Given this list of marker genes Crtc2, Trpv5, Tk1, Gria3, Upb1, Aldh1a2, Trpa1, Mcoln1, Pkm, Aqp2, Pkd2l1, Aqp5, Crtc1, Shmt1, Golga2, Cryz, Aqp4, Mat1a, Sod2, Sycp1, Hprt1, Trpv6, Kcnn4, Tdo2, Trpm7, Itpr1, Samhd1, Acacb, Vasp, Usp16, Dnm1, Evl, Appl2, Trpm2, Gls, Kcnt1, Mip, Cbr4, Gnmt, Ryr3, Hcn1, Thg1l, Trpv1, Acot13, Acaca, Gbp5, Aldh9a1, Crtc3, Hsd17b10, Aldh1a3, Kcnj12, Cby1, Ryr1, Apip, Ssbp1 (NCBI Gene Id 72790), Aldoa, Cth, Pkd2, Osbpl2, Trpm4 (transient receptor potential cation channel, subfamily M, member 4), Shmt2, Kcnj2, B2m, Itpr3, Me1, here is a description of the gene set: The formation of a protein homotetramer, a macromolecular structure consisting of four noncovalently associated identical subunits. studied in species Mus musculus Mouse Gene Set: GOBP_PROTEIN_HOMOTETRAMERIZATION